The following is a description of a gene set: Human Gene Set: GOCC_INTERCALATED_DISC species: Homo sapiens A complex cell-cell junction at which myofibrils terminate in cardiomyocytes; mediates mechanical and electrochemical integration between individual cardiomyocytes. The intercalated disc contains regions of tight mechanical attachment (fasciae adherentes and desmosomes) and electrical coupling (gap junctions) between adjacent cells., and this is the list of marker genes: SCN1A, JUP (junction plakoglobin), NRAP, PGM5, SPTBN4, ATP1B1, ATP2A2, SLC2A1 (solute carrier family 2 member 1), GJC1, PIK3CA, VAMP5, SLC9A1, FHOD1, GJA1, ANKRD23, CDH2, RANGRF, ANK2, SCN5A, DLG1, KCNA5, DSP, VCL, CXADR, CTNNB1, YWHAH, DES, CTNNA1, GJA5, SCN1B, SLC8A1, PAK1, ATP1A2, MYH1, ITGB1, KCNJ2, AKAP6, FGF13, DSG2, CTNNA3, DSC2, PKP2, FXYD1, ANK3, SLC31A1, CAV3, OBSL1, TMEM65, ACTN1, SCN4B